Given this list of marker genes Brf2, Mtor, Snapc3, Snapc4, Maf1, Brf1, here is a description of the gene set: Mouse Gene Set: GOMF_RNA_POLYMERASE_III_TYPE_3_PROMOTER_SEQUENCE_SPECIFIC_DNA_BINDING studied in species Mus musculus Binding to a sequence of DNA that is a part of a type 3 promoter that controls transcription by RNA polymerase III (Pol III). A type 3 Pol III promoter is composed of elements upstream of the transcription start site, including a TATA box. The human U6 snRNA gene has a type 3 promoter. Type 3 Pol III promoters have not been observed in S. cerevisiae.